Given this list of marker genes HOXA9, DSTN, IL2RG, TCF7, LAPTM5, PRSS3, MRPS12, GATA3, DDX5, ADCYAP1, STAT3, PRDX1, KIAA1671, CHI3L2, TNFAIP3, VDAC1, SERINC3, CTSH, SLC7A5, SREBF2, SSR4 (NCBI Gene Id 6748), CREB3, MBOAT7, MME (membrane metalloendopeptidase), TIAM1, CBX3, WAS, SELL, SULT1A3, NFIL3, SNHG14, IFITM2, CCR9, CLCNKA, BTG1, PTPN6, USF2, SPOCK2, PXDN, CBLB, ELAVL3, PRDX2, BMI1, LCP2, AEBP1, VIM, TSC22D1, CAPRIN1, TCF4, FCGRT, FLNA, IL32, PRKAR1B, CD34, FAM30A, FUT7, GDI1, CDH4 (cadherin 4), LPCAT3 (lysophosphatidylcholine acyltransferase 3), MYOM2, FKBP2, ID3, FGR, DMPK, SMAD1, HYOU1, TUBA1A, YBX3, IKZF1, CD3E, GPSM3, NUCB2, SLC35B1, CLEC2B, ALPP, G6PD, BIN1 (NCBI Gene Id 274), RELA, CX3CR1, TLE4, HLA-E, CD47, RALGDS, TRGC1, MAD1L1, PLEC, TPM2 (tropomyosin 2), SPTBN1, NRIP1, here is a description of the gene set: from publication Ferrando AA, Armstrong SA, Neuberg DS, Sallan SE, Silverman LB, Korsmeyer SJ, Look AT (PMID 12637319) Top genes positively associated with T-cell acute lymphoblastic leukemia MLL T-ALL) expressing MLL-ENL fusion. species: Homo sapiens Rearrangements of the MLL locus, located on human chromosome 11q23, are frequent in both infant and therapy-related leukemias. Gene expression analysis of MLL-rearranged B-precursor acute lymphoblastic leukemias (MLL B-ALLs) has identified these cases as a unique subtype of leukemia, characterized by the expression of genes associated with both lymphoid and myeloid hematopoietic lineages. Here we show that MLL fusions also generate a distinct genetic subtype of T-lineage ALL (MLL T-ALL), in which leukemic cells are characterized by an early arrest in thymocyte differentiation, with suggestive evidence of commitment to the gammadelta lineage. Interestingly, multiple genes linked to cell proliferation (eg, PCNA, MYC, CDK2, and POLA) were down-regulated in MLL-fusion samples, relative to those transformed by other T-ALL oncogenes (P <.000 001, Fisher exact test). Overall, MLL T-ALL cases consistently demonstrated increased levels of expression of a subset of major HOX genes--HOXA9, HOXA10, and HOXC6--and the MEIS1 HOX coregulator (P <.008, one-sided Wilcoxon test), a pattern of gene expression that was reiterated in MLL B-ALLs. However, expression of myeloid lineage genes, previously reported in MLL B-ALLs, was not identified in T-lineage cases with this abnormality, suggesting that myeloid gene dysregulation is dispensable in leukemic transformation mediated by MLL fusion proteins. Our findings implicate dysregulation of HOX gene family members as a dominant mechanism of leukemic transformation induced by chimeric MLL oncogenes. Human Gene Set: FERRANDO_T_ALL_WITH_MLL_ENL_FUSION_UP